The following is a description of a gene set: Genes predicted to be targets of miRBase v22 microRNA hsa-miR-1263 in miRDB v6.0 with MirTarget v4 prediction scores > 80 (high confidence targets). from publication Chen Y, Wang X (PMID 31504780) studied in species Homo sapiens Human Gene Set: MIR1263, and this is the list of marker genes: RPS6KA3, TRMT6, ZBTB26, ATAD2, FBXO11, TMEM106C, DYRK1B, KDR, TLCD5, UBE2G1, ZEB2, STX3, SMAD7, WDR41, SLC38A2, DIXDC1, STX16, SLC25A46, C11orf87, CHD7, PDGFRB, TMEM150A, SEM1, ANKS1B, KIAA0040, LRRTM1, CYTH3, FSD1L (NCBI Gene Id 83856), PRP4K, ST8SIA4, CADPS, MAP3K2 (mitogen-activated protein kinase kinase kinase 2), ASAP2, MSI2, ZNF217, KLF4, IDUA, SLC2A1, FBXO28, ANKS1A, LDB1, TLE3, PHLDB1, CSGALNACT2, RGPD3, NAA30, SNAP91, AP3M1, NAA15 (NCBI Gene Id 80155), TOMM20L, CDH2, ATP10A, TMEM179B